Given this list of marker genes CDK14, RSPO3 (NCBI Gene Id 90095), EYA4, AKAP12, TBC1D15, ISL1, ACACA, PDE4B, HNRNPU, LIN7C, TGFBR1, HNRNPK (heterogeneous nuclear ribonucleoprotein K), MTCL2, EIF4B, ELOVL4, TFEC, BACH2, MET (NCBI Gene Id 4233), SLF2, MEOX2, KCNIP3, FOSB, ZNF146, ALPL, OGT, EHMT1, SCHIP1, HSP90B1, MAL2, IVNS1ABP, ALX1, KCNMA1 (potassium calcium-activated channel subfamily M alpha 1), BPNT1, TMEM204, GNPDA2, KCTD12, CSNK1A1, CCDC141, FBXL19, TOX, KHSRP, MSTN, SMIM14, RPS6KB1, MON2, HACD3, EDN1, PBRM1, CLOCK, MAP1A, PPP2CA, MTX3, CHMP2B, GPD2, EAF1, PHF6, PDCD10 (NCBI Gene Id 9226), EDEM3, MATR3, ATP6V1C2, UST, OSGIN2, RHOF, PUM2, FOXP1, ZNF236, GDAP1L1, FBXO33, SEC62, LYST, NR4A2, SMYD4, GPR88, SRSF3, CALML4, ANXA4, HS3ST3B1, FICD, ARCN1, CTNND1, MYLK, MMD, RIC8B, ZNF580, WDR6, BASP1, POGK, SEMA4F, TGFBR3, CDK17, SH3BGRL3, SLC39A10, GJA1, VAMP4, SRSF11, FZD7, LRP2, ZNF280D, CIAO2A, IGF1, NOL4L, DIP2C, TWIST1, CSNK1G1, RNF38, NIPBL, BDNF, CREB5, RSF1, CTNNA2, INTS2, JUN, GRK6, ZNF800, PCDH9, YPEL2, BET1, ANXA2, PTPRF (protein tyrosine phosphatase receptor type F), ZBTB6, BRF2, CACUL1, AP1G1, HDAC4, QKI, MEX3C, HIVEP2, PAX3, FRAS1, SEMA6D, LIN28B, SOX6, HMGN1, NEXMIF, TPM3, NDRG3, USP33, SETBP1, ARHGEF18, UBE2J1, CITED2, AMFR, IP6K2, here is a description of the gene set: studied in species Homo sapiens Genes having at least one occurence of the motif AACATTC in their 3' untranslated region. The motif represents putative target (that is, seed match) of human mature miRNA hsa-miR-409-3p (v7.1 miRBase). Human Gene Set: AACATTC_MIR4093P